The following is a description of a gene set: part of: Fatty acyl-CoA biosynthesis This event has been computationally inferred from an event that has been demonstrated in another species.<p>The inference is based on the homology mapping from PANTHER. Briefly, reactions for which all involved PhysicalEntities (in input, output and catalyst) have a mapped orthologue/paralogue (for complexes at least 75% of components must have a mapping) are inferred to the other species. Reactome Pathway: Synthesis of very long-chain fatty acyl-CoAs electronically inferred by orthology from the curated human pathway studied in species Mus musculus, and this is the list of marker genes: Elovl3, Acsl6, Hacd1, Elovl7, Hacd2, Hacd4, Acsf3, Elovl5, Acsl4, Elovl2, Hsd17b3, Tecrl